Given this list of marker genes ZNF827, KNTC1, SGF29, ATRX, BOD1, H4C11, NIPBL, TOPBP1, MRNIP, RAD21, H4C1, LEF1, TNKS, XRCC4, MDC1, NBN, MCM8, SETD2, TNKS2, BRD2, ESR1, SPDL1 (NCBI Gene Id 54908), VCPIP1, H4C14, CTCFL, MTBP, BUB3, TPP1, ATR, RCC2, WAPL, BUB1B, H2BC11, PINX1, H4C4, ZMYND8, RUVBL2, JARID2, RAD17, HTATSF1, TP53BP1, TERF1 (telomeric repeat binding factor 1), H2AC8, SLF1 (NCBI Gene Id 84250), H4C8, IK, TERT, PPHLN1, SPDYA, BRD3, SPIDR, ESCO2, TONSL, MACROH2A1, ACD, GNL3, INTS6, H1-5, SMC5, IFFO1, SPO11, NABP2, RPA1, HASPIN, SLF2, H4C9, LNCPRESS1, AURKB, H4C13, TERF2, RNF4, RB1, H4C2, PARP1, CTCF, WRAP53, TINF2, CHAMP1, CDK9, VCP, POT1 (protection of telomeres 1), USP7, CENPA, INTS8 (NCBI Gene Id 55656), PIAS4, H4C16, RHNO1, H4C15, EZH2, FAM47E, MACROH2A2, PML, CCT6A, CHMP7, APLF, LRWD1, WBP2, CYREN (NCBI Gene Id 78996), KNL1, CENPQ, H2AC4, RPA2, SPIN1, MIS18A, H2AX, XRCC5, SPI1, SIRT6, ZW10, H4C12, TERF2IP, CDK1, H4C6, H4C3, H4C5, TRAPPC12, MCM9, TASOR, TTK (TTK protein kinase), ZWILCH, VRK1, LEMD2, PLK1, GNL3L, PARP3, TCP1, MMS22L, BRCA2, here is a description of the gene set: Human Gene Set: GOBP_PROTEIN_LOCALIZATION_TO_CHROMOSOME species: Homo sapiens Any process in which a protein is transported to, or maintained at, a specific location on a chromosome.